The following is a description of a gene set: Human Gene Set: MIR4789_3P Genes predicted to be targets of miRBase v22 microRNA hsa-miR-4789-3p in miRDB v6.0 with MirTarget v4 prediction scores > 80 (high confidence targets). from publication Chen Y, Wang X (PMID 31504780) species: Homo sapiens, and this is the list of marker genes: ACE, NR1D2, PROX1, CLEC4C, SYTL4, B4GALT6, GCOM1, REV3L, ELMOD2, RORA, DIPK1C, KITLG, RAPH1 (Ras association (RalGDS/AF-6) and pleckstrin homology domains 1), CPEB2, FBXO11, YWHAE, SHOC2, INTS6L, CREB1, MRTFB, RAB31, KDM6A, TBC1D22B, SLC25A3, COL1A1, PURA, CDK17, GABPA, TMEM26, ANO5, COL4A1, HOMER1, PHIP, STARD13, PHF14, DENND4C, PCSK2, KRTAP24-1, RPGR, ANKRD11, MARCHF6, LEMD3, IL17C, HMX2 (H6 family homeobox 2), MORF4L2, PPP1R1C (NCBI Gene Id 89799), EPS8L2, SHPRH, REEP3, RBP3, SOCS6, CD200R1, C8orf34, KLF7, GPR137C, PREX2, GRIA2, HDGFL3, ZNF618, LRRIQ4, TENT5A, FAM184A, CALHM5, STXBP3, KLHL23, GPR63, GABRB2, PCDH18, NUS1, ACTR3, KCNG3, PPM1K, MID2, SMC6, USP25, PLCB4, IFNA21, PCLO, TFAP2A, MRPL14, YWHAB, TNRC6B, SLC35F3, CASZ1, C5orf24, PM20D2, BTAF1, COL19A1 (NCBI Gene Id 7950), FRY, FSTL5, LRP8, ATXN7L3B, ZNF829, PDLIM5, STXBP5, RAB9A, NUFIP2, MARK1, EIF1, YTHDC2, RAPGEF4, PRLR, MOB4, BMPER, ZNF518B, TAF4B, UNC80, NANP, C18orf21, MLLT3, PTPRR, CACNG3, GBP5, MEIS2, NMUR1, MERTK (NCBI Gene Id 10461), EPCAM, NR5A2, ZYG11B, RUNX1T1 (RUNX1 partner transcriptional co-repressor 1), ZSWIM5, KIT, C19orf12, RNF44, BHLHE22, EGR3, ATPSCKMT, PPAT, LHFPL2, CASD1, ATP7A, PCDH7, ARHGAP26, NUBPL, GRIN2A, DLC1, PHF13, DIO2, HMGXB4, SSBP2, PPM1A, CXCL2, UBTF, ZNF367, ZNF681, AHSA1, XPO1, SPRED1, FRMPD4, RAB6B, CLVS1, ELK4, NR2C2, PTPN4, GLUD1, CAMSAP2, INO80D, DGKH, ISL1, UNKL, ZXDC, PCF11, GRM3, EPB41L5, CASK, SRGAP3, PCDHB4, VSTM2A, HAUS2, VAV3, CREBZF (CREB/ATF bZIP transcription factor), SLC6A1, AZIN1, COL21A1, ZNF254, PKN2 (NCBI Gene Id 5586), DOCK10, TRIO, SMAP2, THUMPD2, ZNF91, SGK1, RBM12, POLR2F, ZBTB5, NPAS3, ZNF670, PGAP1, CFAP47, GTF2I, AQR, CAMK4, MYO9B, TMEM144, STEAP3, AKIRIN1, FRMD3, KLHL28, TATDN3, MRS2, MAGEA2B, SPIN1, CENPI, DST, ARHGAP5, ACTR6 (actin related protein 6), CMPK2, PNRC1 (proline rich nuclear receptor coactivator 1), HSPE1-MOB4, NRF1, BAZ2B (NCBI Gene Id 29994), SLC30A5, FAM222B, HOXD3, GABRB3, BCLAF3, RNF180, USP3, SESN3, USP53, TRIQK, HYCC2, PEX5, CHIC1, SMOC2, DIAPH2, TYRP1, COPS2, ARHGAP6, ARID3B, GNAI1, LMO7DN, YWHAQ, PAIP1, MBNL2, BMF, ATP6V1A, DPPA4, PKD2 (NCBI Gene Id 5311), DNPEP, TCEAL7, SLC12A2 (solute carrier family 12 member 2), DCUN1D4, CACNA1G, ANGPT1, UNK, KLHL3, CDYL2, IRS1, MEF2C, ZSWIM6 (NCBI Gene Id 57688), RBPJ, PI15, FUT9, CA8, TENM1, DDHD2, RICTOR, AMPH, CDC14A, GPR180, MNT, CUL3, CIAO2A, FAN1, NTRK2, CKS2 (NCBI Gene Id 1164), CDH11, ATP13A3, ADCYAP1, TNFRSF19, UBE2Q1, ZNF124, ARAP2, ERP44, LIN28B, ELL2, OSBPL11, RNASE4, PDE3B, SOX21, ARHGEF38, RIMKLB, L2HGDH, EPHA4, B3GALT1, KDM4C, KCNA2, CPSF6, CYCS, TGFB2, PLAG1, DNAJC25, TMPRSS15, HERPUD2, SART3, CCDC186, ZNF230, TBC1D31, FGFR2, FMNL2, DOCK4, ARHGEF10L, YRDC, BCL6, GUCA1B, SYNJ1, CHSY1, SLC44A1, CNOT2, STK3, PPARGC1A, SCAI, PLPP5, LIPA, ARHGAP24, NXPE3, LARP1B, DZANK1, SLC6A19, NIN, DEPDC1, POLR2M, MAP1LC3B, PIK3R1, SLC35G1, PLCXD1, KCNQ3, SRGAP2B, TMEM196, SLC7A11, ADAMTS9, MAGEA2, DYNLL2, TMCC1, SERPINB8, ST8SIA4, ADAMTS18, UTY, TMPRSS12, CNOT6L, THBS2, XRN1